The following is a description of a gene set: Binding to a sequence of DNA that is part of a core promoter region. The core promoter is composed of the transcription start site and binding sites for the RNA polymerase and the basal transcription machinery. The transcribed region might be described as a gene, cistron, or operon. Human Gene Set: GOMF_CORE_PROMOTER_SEQUENCE_SPECIFIC_DNA_BINDING species: Homo sapiens, and this is the list of marker genes: CEBPB, UBTFL1, PAX6, RUVBL2, TAF1, TBPL1, AGO2, ZBTB17, TAF1B, RFX7 (NCBI Gene Id 64864), DRAP1, SMARCB1, RRN3, SNAPC3, KLF10, TBP, H3-3A, H2AZ1, STAT1, NR3C1, REST, GTF2A1, GTF2B, POU2F1, JPH2, TP53, UBTFL6, FOXP1, TAF1C, RELA, NPM1, MYC, FOS, SMARCA4, EZH2, ISL1, HDAC1, TAF4, UBTF, MMP12 (NCBI Gene Id 4321), BAZ2A (bromodomain adjacent to zinc finger domain 2A), H3-3B, AR, PARK7, AGO1, GBX2